Given this list of marker genes Igf1, Mup2, Csf1r, Epha1, Ephb2, Areg, Ptk7, Dgkq, Tek, Epha10, Epha6, Igf1r, Epgn, Hbegf, Pdgfra, Tie1, Alkal2, Grem1, Insr, Kdr, Angpt4, Ly6g6e, Mup4, Tgfbr3, Lilrb4b, Lilrb4a, Ephb1, Tgfbr3l, Bmpr1b, Egfr, Ins2, Epha4, Ins1, Tgfa, Sostdc1, Ephb6, Amhr2, Ntrk1, Mup3, Mup1, Egf, Flt3, Ret, Alkal1, Igf2, Fgfrl1, Flt1, Erbb4, Acvr2a, Flt4, Ngf, Ntrk2, Musk, Ltk, Axl, Met, Fgfr3, Epha2, Pdgfrb, Ror2, Tgfbr1, Tyro3, Ror1, Ros1, Mup11, Acvr2b, Nrp2, Hjv, Acvr1, Mertk, Epha8, Insrr, Ephb4 (Eph receptor B4), Nrp1, Ddr1, Mup5, Acvr1b, Erbb2, Ephb3, Ddr2, Bmpr1a, Fgfr4, Fgfr2, Ereg, Btc, Alk, Efemp1, Mst1r, Epha3, Bmpr2, Nrg2, Acvr1c, Kit, Vegfa, Ntrk3, Fgfr1, Tgfbr2, Acvrl1, Epha7, Ryk, Epha5, here is a description of the gene set: Combining with a signal and transmitting the signal from one side of the membrane to the other to initiate a change in cell activity by catalysis of the reaction: a protein + ATP = a phosphoprotein + ADP. Mouse Gene Set: GOMF_TRANSMEMBRANE_RECEPTOR_PROTEIN_KINASE_ACTIVITY studied in species Mus musculus